Given this list of marker genes GSG1, IDO1, MARCKS, FOXG1, MMP10, SEMA6A, ROBO2, PBDC1, TES, FZD8 (NCBI Gene Id 8325), AKR1C1, BAMBI, CFHR1, ZFP42, MEST, PSG8, CFH, SKAP1, EDNRB, PPIC, JAG1, PCDH7, AKR1C3, CHRDL1 (NCBI Gene Id 91851), ADM (NCBI Gene Id 133), PSG11, XIRP2, AMIGO2, LAMA4, TDO2, ADGRG6 (NCBI Gene Id 57211), DSEL, GPC3, here is a description of the gene set: The molecular pathways activated in response to acute cisplatin exposure, as well as the mechanisms involved in the long-term development of cisplatin-resistant cancer cells remain unclear. Using whole genome oligonucleotide microarrays, we have examined the kinetics of gene expression changes in a cisplatin-sensitive cell line, A2780, and its cisplatin-resistant derivative, ACRP. Both sensitive and resistant cell lines exhibited a very similar response of p53-inducible genes as early as 16 h after treatment. This p53 response was further increased at the 24-h time point. These experiments identify p53 as the main pathway producing a large-scale transcriptional response after cisplatin treatment in these cells containing wild-type p53. Consistent with a role for the p53 response in cisplatin sensitivity, knockdown of the p53 protein with small interfering RNA led to a twofold decrease in cell survival in the resistant cells. In addition, our analysis also allowed the identification of several genes that are differentially expressed between sensitive and resistant cells. These genes include GJA1 (encoding connexin 43 (Cx43)) and TWIST1, which are highly upregulated in cisplatin-resistant cells. The importance of Cx43 in drug resistance was demonstrated through functional analyses, although paradoxically, inhibition of Cx43 function in high expressing cells led to an increase in drug resistance. The pathways important in cisplatin response, as well as the genes found differentially expressed between cisplatin-resistant and -sensitive cells, may represent targets for therapy aimed at reversing drug resistance. Human Gene Set: LI_CISPLATIN_RESISTANCE_DN Genes consistently down-regulated in ACRP cells (ovarian cancer, resistant to cisplatin) compared to the parental sensitive A2780 cells, regardless of cisplatin exposure. studied in species Homo sapiens from publication Li J, Wood WH 3rd, Becker KG, Weeraratna AT, Morin PJ (PMID 17072341)